Given this list of marker genes METTL18, ZMIZ2, PML, ESCO1, CAPN3, TRPM4, RASD2, VIPAS39, SIRT4, BLOC1S1, UHRF2, SIRT2, NNAT, PLOD3, KAT7, ARNT, RANGAP1, EEF1AKMT1, SUMO2, DOHH, UBA2, SMYD2 (NCBI Gene Id 56950), CSKMT, VCPKMT, TRIM28 (NCBI Gene Id 96054), BAG6, LIPT2, GNL3L, NDUFAB1, EHMT2, P3H4, NFATC2IP, DIP2B (disco interacting protein 2 homolog B), EGR1, SENP3, EYA1, ZNF451, HDAC4, ANTKMT, FSCB, NAT8B, PLOD1, EEF1AKMT3, IFIH1, EP300, CTH, EEF1AKMT2, PIAS2, DIP2A, KAT2B, NAT8, SAE1, SMC6, SUMO1P1, PIAS3, CTNNB1, NSMCE2, SIRT1, PLOD2, P3H3 (NCBI Gene Id 10536), HMG20A, EHMT1, SLF1, SMC5, SIRT5, BCL11A (BCL11 transcription factor A), SUMO4, TOPORS, MUL1 (NCBI Gene Id 79594), SIRT3, EID3, TRIM27, HINT1, NSMCE3, KMT5A (NCBI Gene Id 387893), USPL1, MAGEA2, ATAT1, SETD3, CBX4, DESI1, HMG20B, CREBBP, KIAA1586 (NCBI Gene Id 57691), PIAS1, IVL, LOXL2, SUMO3, EEF2KMT, SENP5, ZMIZ1, TRIM38, ZBED1 (zinc finger BED-type containing 1), METTL21C, STX1A, KAT2A, KLF15, JMJD6 (NCBI Gene Id 23210), RELA, CDKN2A, SUMO1, EGR2, SLF2, SETD2, RNF212, SENP6, LOX, PIAS4, RWDD3, HDAC9, LOXL3, GNL3, NSMCE4A, SENP7, SETD7, DHPS, SENP2, KAT5, RANBP2, HDAC7, UBE2I, NSMCE1, SENP1, PARK7, VPS33B, TOLLIP, ATPSCKMT, MDM2, MAGEA2B, SETD6, here is a description of the gene set: Human Gene Set: GOBP_PEPTIDYL_LYSINE_MODIFICATION The modification of peptidyl-lysine. species: Homo sapiens